Given this list of marker genes EFNA1, CCL2, PLA2G6, SLC4A7, DUSP5, CTSB, ATF3, FGG, STAT2, ABCA1, AKAP12, TRIB1, KLF11, THBS1, PLIN3, STAT3, FLNB, SAMD4A, TEAD4, LDLR, PLPP3, SOD2, IGFBP1, SLC2A14, ICAM1, BCL3, AGT, JUN, PFKFB3, CEBPD, LBP, SERPINB3, FEM1C, SLC2A3, PALM2AKAP2, UGCG, C3, ADM, FGB, EFNB2, FOSL1, HEG1, GFPT2, NPC1, BCL6, ZFP36, SOCS3, FGA (NCBI Gene Id 2243), here is a description of the gene set: Top genes up-regulated in A549 cells (lung cancer) expressing STAT3 off an adenovirus vector. Human Gene Set: DAUER_STAT3_TARGETS_UP from publication Dauer DJ, Ferraro B, Song L, Yu B, Mora L, Buettner R, Enkemann S, Jove R, Haura EB (PMID 15735721) Wound healing and cancer are both characterized by cell proliferation, remodeling of extracellular matrix, cell invasion and migration, new blood vessel formation, and modulation of blood coagulation. The mechanisms that link wound healing and cancer are poorly understood. We report here that Stat3, a common signaling mechanism involved in oncogenesis and tissue injury, regulates a common set of genes involved in wound healing and cancer. Using oligonucleotide gene arrays and quantitative real-time PCR, we evaluated changes in global gene expression resulting from expression of Stat3 in lung epithelial cells. We report here previously uncharacterized genes induced by Stat3 implicated in signaling pathways common to both wound healing and cancer including cell invasion and migration, angiogenesis, modulation of coagulation, and repression of interferon-inducible genes. Consistent with these results, we found increased Stat3 activity associated with wound healing in chronically inflamed mouse lungs and increased Stat3 activity was identified at the leading edge of lung tumors invading adjacent nontumor stroma. These findings provide a molecular basis for understanding cancer as a deregulation of normal wound healing processes. studied in species Homo sapiens